The following is a description of a gene set: part of: Resolution of AP sites via the single-nucleotide replacement pathway Reactome Pathway: Abasic sugar-phosphate removal via the single-nucleotide replacement pathway electronically inferred by orthology from the curated human pathway species: Mus musculus This event has been computationally inferred from an event that has been demonstrated in another species.<p>The inference is based on the homology mapping from PANTHER. Briefly, reactions for which all involved PhysicalEntities (in input, output and catalyst) have a mapped orthologue/paralogue (for complexes at least 75% of components must have a mapping) are inferred to the other species., and this is the list of marker genes: Apex1